Given this list of marker genes MIR3156-3, POTED, RBMX2P1, TERF1P1, GAPDHP16, ERLEC1P1, GTF2IP2, ZNF355P, ENSG00000232884, ENSG00000224905, ANKRD30BP2, BNIP3P43, GRAMD4P1, ZNF114P1, NF1P3, LIPI, PPP6R2P1, RNU6-614P, ABCC13, RNU6-286P, POLR2CP1, CXADRP1, SNX18P13 (NCBI Gene Id 100419042), FGF7P2, MIR8069, OR4K11P (olfactory receptor family 4 subfamily K member 11 pseudogene), FEM1AP1, RNA5SP488, SAMSN1-AS1, SNX19P1, ANKRD30BP1, CNN2P7, HSPA13, LINC01674, FAM207CP, RHOT1P2, ANKRD20A18P, LONRF2P5, RNU6-954P, FRG2MP, VN1R8P, MIR3118-1, RBM11, SAMSN1, ANKRD20A11P, GXYLT1P2, CYP4F29P, OR4K12P, here is a description of the gene set: Human Gene Set: chr21q11 species: Homo sapiens